Given this list of marker genes CPSF4, UBXN4 (NCBI Gene Id 23190), IK, SNX4, SNX1 (NCBI Gene Id 6642), UFD1, ATXN2, OARD1, CLN3, SDHC, EIF2S1, CAPZB, DUSP11, CUX1, ATP6V0D1, RALB, ARCN1, ILVBL, ZFTRAF1, NFATC2IP, FOXK2, SSR1, DPM1, SEC22B, EIF2B2, PRPF18, FAF2, ZNF410, PSMB6, PDCD10, SNAPC5, TAF9, RAC1, PSMA5, BLOC1S1, FBXW11, METAP1, MTFR1, MRPL28, POLR3C, ZZZ3, NUBP1, RAE1, TOR1AIP1, XPA, SMAD2, SMNDC1, SPCS2, PPP2R5E, PRPF4, BAG1, PSMD10, RAF1, SCRIB, PSEN1, TPR, NKRF, COIL, CDK8, PSMC2, NUP88, TBPL1, PARG, CENPB, RAB11A, MEA1, ZNHIT1, PIGF, DNPEP, HTATSF1, FMR1, STXBP3, RPRD2, SP3, PRPSAP1, METTL18, RAB1A, ZNHIT3, ORC5 (origin recognition complex subunit 5), MYL11, SLC10A3, PEX11B, SHMT1, here is a description of the gene set: studied in species Homo sapiens Human Gene Set: MORF_PPP2R5E Neighborhood of PPP2R5E Neighborhood of PPP2R5E protein phosphatase 2, regulatory subunit B (B56), epsilon isoform in the MORF expression compendium